The following is a description of a gene set: Human Gene Set: HP_ABNORMALITY_OF_SUBCUTANEOUS_FAT_TISSUE species: Homo sapiens Abnormality of subcutaneous fat tissue, and this is the list of marker genes: BSCL2, MEN1, FH, PTEN, FGFR1, GNAS, ATRX, SLC2A2, ERCC8, PDE11A, IGF1R, NAA10, ATP6V0A2, NR3C1, SKI, CYP27B1, LMNA, PTF1A, PIK3CA, COL1A1, CDH23, BRAF, ALG8, PRKAR1A (NCBI Gene Id 5573), ADAMTS2, PPARG, COL1A2 (collagen type I alpha 2 chain), AGPAT2, KCNJ6, AKT1, PLIN1, USP48, LEMD2, SLC25A24, ARMC5 (armadillo repeat containing 5), PRKACA, BMPR1A, USP8, CAV1, KCNK9, SOX18, TGFB3, ATP6V1E1, ADRA2A, INSR, TP53, FBN1, RBM28, TOP3A, PIK3R1, TGFB1, PMM2, GNB2, CDKN1B, TRMT10A, ALMS1, KDM1A, PHGDH, ATP6V1A, ADAMTSL2, H4C5, PPP1R15B, POLR3A, ERCC6, ZMPSTE24, TBL1XR1